Given this list of marker genes TLR3, FADD, CASP8, TICAM1, RIPK3, RIPK1, here is a description of the gene set: Human Gene Set: REACTOME_TLR3_MEDIATED_TICAM1_DEPENDENT_PROGRAMMED_CELL_DEATH TLR3-mediated TICAM1-dependent programmed cell death studied in species Homo sapiens